Given this list of marker genes SMPD2, GNRHR, EIF2B1, SMARCD1, ECM2, AVPR1A (NCBI Gene Id 552), CYTH1, GDI1, SNAPC1, CD80, SNRPB2, EEF1G, STS, SNAPC3, here is a description of the gene set: Human Gene Set: BANDRES_RESPONSE_TO_CARMUSTIN_WITHOUT_MGMT_24HR_UP from publication Bandres E, Andion E, Escalada A, Honorato B, Catalan V, Cubedo E, Cordeu L, Garcia F, Zarate R, Zabalegui N, Garcia-Foncillas J (PMID 15980968) species: Homo sapiens Genes up-regulated in A172 cells (glioma, does not express MGMT) by carmustine at 24 h. Chemotherapy with the alkylating agent BCNU (1,3-bis (2-chloroethyl)-1-nitrosourea) is the most commonly used chemotherapeutic agent for gliomas. However, the usefulness of this agent is limited because tumor cell resistance to BCNU is frequently found in clinical brain tumor therapy. The O6-methylguanine-DNA methyltransferase protein (MGMT) reverses alkylation at the O6 position of guanine and we have reported the role of MGMT in the response of brain tumors to alkylating agents. However, the different mechanisms underlying the patterns related to MGMT remain unclear. To better understand the molecular mechanism by which BCNU exerts its effect in glioma cell lines according MGMT expression, we used microarray technology to interrogate 3800 known genes and determine the gene expression profiles altered by BCNU treatment. Our results showed that treatment with BCNU alters the expression of a diverse group of genes in a time-dependent manner. A subset of gene changes was found common in both glioma cell lines and other subset is specific of each cell line. After 24 h of BCNU treatment, up-regulation of transcription factors involved in the nucleation of both RNA polymerase II and III transcription initiation complexes was reported. Interestingly, BCNU promoted the expression of actin-dependent regulators of chromatin. Similar effects were found with higher BCNU doses in MGMT+ cell line showing a similar mechanism that in MGMT-deficient cell with standard doses. Our data suggest that human glioma cell lines treated with BCNU, independently of MGMT expression, show changes in the expression of cell cycle and survival-related genes interfering the transcription mechanisms and the chromatin regulation.